Given this list of marker genes HTRA1, SKOR2, MIR100, CTDSPL2, MIR26A1, TWSG1, ATF2, SCUBE3, MAPK3, SFRP1, ACVR2B, PRMT1, SOSTDC1, BMP4, DLX1, ETV2, SMAD2, SMPD3, HJV, TGFBR3, SOX9, MIR125B1, HES1 (hes family bHLH transcription factor 1), PDCD4, ACVRL1, PHOX2B (paired like homeobox 2B), MIR30B, CHRDL1, SOST, SMAD9, ACVR2A, UBE2D1, CHRDL2, GDF3, TNFAIP6, SKI, XIAP, HEYL, MTMR4, SFRP4, ARK2C, GATA3, SKOR1, HFE, VWC2L, HTRA3, HES5, GPR155, ID1, GREM2, RUNX2, AMHR2, SULF1 (NCBI Gene Id 23213, sulfatase 1), COL2A1, FSTL3, BMP6, USP15, LEMD3, BMPER, ADAMTS12, MIR140, RGMA, DAND5, FOXD1, GDF7, BMPR1B, NOG, WNT5A, ITGA3, TMPRSS6, UBE2D3, WNT1, VWC2, FSTL4, GATA4, SMAD1, UBE2O, BAMBI, SPINT1, LEF1, CCN1, CRIM1, ENG, MSX1, SMAD5, SPART, FST, CAV1, CDH5, BMPR2, DKK1, MIR98, DLX5, SKIL, FSTL1, SPINT2, ELAPOR2, LRP2, TOB1, SMAD6, FAM83G, GDF2, NEO1, MIR214, DSG4, PPM1A, TRIM33, RGMB, DLX3, MIR210, BMP7, CHRD, MIR93, EGR1, MIR106A, DDX5, MIR195, KDR, ZNF423, GATA5, GATA6, FKBP8, TMEM100, MIR302C, COMP (cartilage oligomeric matrix protein), SOX11, KCP, BMPR1A, HOXA13, FZD1, ABL1, TMEM53, HIPK2, TMEM119, ILK, USP9Y, ZNF8, MIR885, ACVR1, EXT1, RBPMS2, GPC3, VSTM2A, GDF5, SMAD7, MIR20A, TFAP2B, SORL1, NFIA, MIR21, PCSK6, SMAD5-AS1, TBX20 (NCBI Gene Id 57057), MIR199A1, CER1, BMP2, GREM1, PELO, FBXL15 (F-box and leucine rich repeat protein 15), BMP10, RBPJ, NUMA1, HIVEP1, ERFE, NGLY1, FBN1, NOTCH1, SCX, USP9X, NBL1, BMP5, MIR199B (NCBI Gene Id 406978), SMURF2, NOTCH2, SMAD4, POU5F1, SFRP2, ADAMTS7, MSX2, GDF6, FSTL5, CRB2, PPARG, MICOS10-NBL1, SMURF1, MEGF8, SLC39A5, here is a description of the gene set: Human Gene Set: GOBP_RESPONSE_TO_BMP Any process that results in a change in state or activity of a cell or an organism (in terms of movement, secretion, enzyme production, gene expression, etc.) as a result of a bone morphogenetic protein (BMP) stimulus. studied in species Homo sapiens